Given this list of marker genes SV2A, VAMP2, VAMP1, SYT2, SV2C, STX1A, STX1B, SNAP25, SV2B, SYT1, here is a description of the gene set: Neurotoxicity of clostridium toxins species: Homo sapiens Human Gene Set: REACTOME_NEUROTOXICITY_OF_CLOSTRIDIUM_TOXINS